Given this list of marker genes Hrg, Enpp4, Nfe2l2, Ano6, F2r, Vwf, Apoh, Tbxa2r, Plau, Serpinf2, St3gal4, S100a9, Emilin1, Hpse, Plat (plasminogen activator, tissue), F12, Vtn, Plg, Cpb2, F7, Thbs1, Cd36, Emilin2, Prdx2, F2, Serpine1, here is a description of the gene set: studied in species Mus musculus Any process that activates or increases the frequency, rate or extent of hemostasis. Mouse Gene Set: GOBP_POSITIVE_REGULATION_OF_HEMOSTASIS